The following is a description of a gene set: Human Gene Set: GOBP_NEGATIVE_REGULATION_OF_MICROTUBULE_POLYMERIZATION_OR_DEPOLYMERIZATION Any process that stops, prevents, or reduces the frequency, rate or extent of microtubule polymerization or depolymerization. studied in species Homo sapiens, and this is the list of marker genes: APC (NCBI Gene Id 324), HDAC6, MAPRE1, TPX2, GAS2L1, INPP5J, HDGFL3, APC2, BBOF1, MID1IP1, CAMSAP2, SPEF1 (NCBI Gene Id 25876), CCDC88C, CLIP3, FKBP4, BMERB1, TRIM54, STMN2, SNCA, GAS2L2, EML2, CKAP2, DIAPH3, TTBK2, ARHGEF2, TUBB4A, MAP6D1, DYRK1A, TAOK1, KATNB1, FGF13, CDH5, CLASP2, MAP1B, MID1, ATXN7, SPECC1L, MAP2, NAV3, CLASP1 (cytoplasmic linker associated protein 1), WDR47, TBCD, STMN1, CIB1, ARHGEF7